Given this list of marker genes REEP6, FHOD3, ITGB1, H1-3, DHH, FST, BUB1, FOXL2, LRP5, HMGB2, CHGB, H1-5, LMBR1L, ANKRD6, LAMA1, PTGES, RBP1, AMH, MAGED2, H3C7, RALB, CORO2A, H2AC11, INHBB, CKB, VCAN, H2AC8, IFI27, CDH3, HSPG2, H4C15, FAM110C, SPINT2, NECTIN1, RIMS4, PRRT1, HSD17B1, ALDH18A1, GREM1, CCDC69, PPP1R13B, VPS8, IHH, CCND2, STMN3, ST6GAL2, CRHBP, H2BC8, MEX3B, HDHD3, LY6E, H3C2, SLC16A1, H2BC10, H3C15 (NCBI Gene Id 449003), TNNI3, LPL, H4C12, ADCK2, H4C6, DAG1, H3C6, PSMA3, PRR15, HS6ST1, SRPX, SERPINE2, FAM78A, CEACAM21, APOBEC3C, CENATAC, STMN1, SFXN3, PRAME, FSCN1, H2BC9, MYO10, MFAP2, PRSS23 (NCBI Gene Id 11098), CD99, H2BC5, H3C8, ATP5IF1, BEX1, CDH2, TSPAN7, VEGFA, CKAP2, H3C13, LIMS2, SLC47A1, H2AC19, PRKAR2B, PLEKHH1, ANXA6, PPP1R13L, here is a description of the gene set: Human Gene Set: JONES_OVARY_GRANULOSA studied in species Homo sapiens The reproductive and endocrine functions of the ovary involve spatially defined interactions among specialized cell populations. Despite the ovary's importance in fertility and endocrine health, functional attributes of ovarian cells are largely uncharacterized. Here, we profiled >genes in 257 regions from the ovaries of two premenopausal donors to examine the functional units in the ovary. We also generated single-cell RNA sequencing data for 21,198 cells from three additional donors and identified four major cell types and four immune cell subtypes. Custom selection of sampling areas revealed distinct gene activities for oocytes, theca, and granulosa cells. These data contributed panels of oocyte-, theca-, and granulosa-specific genes, thus expanding the knowledge of molecular programs driving follicle development. Serial samples around oocytes and across the cortex and medulla uncovered previously unappreciated variation of hormone and extracellular matrix remodeling activities. This combined spatial and single-cell atlas serves as a resource for future studies of rare cells and pathological states in the ovary. from publication Jones ASK, Hannum DF, Machlin JH, Tan A, Ma Q, Ulrich ND, Shen YC, Ciarelli M, Padmanabhan V, Marsh EE, Hammoud S, Li JZ, Shikanov A (PMID 38578993)